The following is a description of a gene set: Neighborhood of PTEN phosphatase and tensin homolog (mutated in multiple advanced cancers 1) in the MORF expression compendium Neighborhood of PTEN studied in species Homo sapiens Human Gene Set: MORF_PTEN, and this is the list of marker genes: PAX9, CDYL, STAG1, CTRL, GJB5, ELAVL2, ZP2, KRT33A, GPR19, PAXIP1, RBMXL1, FOSL1, ZNF253, DNAJC16, SCAMP1, MSL3, MC5R (melanocortin 5 receptor), ZNF266, RAP2C (RAP2C, member of RAS oncogene family), ZNF134, BRD1 (bromodomain containing 1), ABCB10, ARFGEF2, KRT86, PTBP3 (polypyrimidine tract binding protein 3), IGKV7-3, AQP7, MSH3, PHF10, KIAA0586, SULT2B1, FNTB, PIAS2, RPS6KA5, PTEN, IL13RA1 (interleukin 13 receptor subunit alpha 1), ZNF157, MGA, POP4, P2RY10, ATF2, GRIK5, NRTN, INPP5E, PVR, KRR1, FRYL, GPATCH8, MLLT10 (NCBI Gene Id 8028), MAGEA9, UBE4B, POU6F1, TMEM11, ATP6V0A2, CYP11A1, CNTN6, BNIP1, FRY, JRK, ZBTB22, POLR2K, TBC1D22A, CPEB3, SULT4A1, PSMF1, KRT2 (keratin 2), WIPF2, HNF1A, ZNF500, NTNG2, PIK3CB, COX6A2, SLC33A1, IL16, SYT5, TBX19, TFDP2, NR1I2, WBP4, ZBTB14, NFX1, GLE1, JADE3, MFN1, PPP1R3D